Given this list of marker genes Lgals1, Cd63, Fn1, Mcam, Pbk, Tagln2, Rnf213, B2m, Pdgfra, Tpm1, Rps27l, Hnrnpa1, Cd9 (CD9 antigen), Serpine2, Ppp1r18, Stat3, Nin, Ppp1r14b, Cdk1, Hmox1, Dynlt1b, Rrm2, Plk1, Dbi, 9430015G10Rik, Ost4 (NCBI Gene Id 67695), Hmgb2 (high mobility group box 2), Marcks, Ftl1, Marcksl1, Eef1a1, Rplp0, Cdc42se1, Chst11, Ccnd2, Tpm4, Ppfibp1, Pcna, Hspa14, Fos, H2-Eb1, Mki67, Ybx1, Top2a, Epn2, Mcm2, Mcm3, Rev3l, Sdc3, Klf6, Spp1, Ccnd1, Frmd8, Cdk4, Cdc20, Sulf2, Tmem176b, here is a description of the gene set: Genes up-regulated in brain tumors induced by retroviral delivery of PDGFB. Mouse Gene Set: JOHANSSON_GLIOMAGENESIS_BY_PDGFB_UP Retroviral tagging previously identified putative cancer-causing genes in a mouse brain tumor model where a recombinant Moloney murine leukemia virus encoding the platelet-derived growth factor B-chain (MMLV/PDGFB) was intracerebrally injected in newborn mice. In the present study, expression analysis using cDNA arrays revealed several similarities of virus-induced mouse gliomas with human brain tumors. Brain tumors with short latency contained on average 8.0 retroviral insertions and resembled human glioblastoma multiforme (GBM) whereas long-latency gliomas were of lower grade, similar to human oligodendroglioma (OD) and had 2.3 insertions per tumor. Several known and novel genes of tumor progression or cell markers were differentially expressed between OD- and GBM-like tumors. Array and quantitative real-time PCR analysis demonstrated elevated expression similar to Pdgfralpha of retrovirally tagged genes Abhd2, Ddr1, Fos, Ng2, Ppfibp1, Rad51b and Sulf2 in both glioma types compared to neonatal and adult normal brain. The retrovirally tagged genes Plekhb1, Prex1, Prkg2, Sox10 and 1200004M23Rik were upregulated in the tumors but had a different expression profile than Pdgfralpha whereas Rap1gap, Gli1, Neurl and Camk2b were downregulated in the tumors. The present study accentuates the proposed role of the retrovirally tagged genes in PDGF-driven gliomagenesis and indicates that insertional mutagenesis can promote glioma progression. from publication Johansson FK, Göransson H, Westermark B (PMID 15750623) species: Mus musculus